The following is a description of a gene set: Mouse Gene Set: GOMF_PROTEIN_TRANSPORTER_ACTIVITY species: Mus musculus Directly binding to a specific protein and delivering it to a specific cellular location., and this is the list of marker genes: Tomm20l, Bcs1l, Tomm70a, Tomm40, Tmed10-ps, Gga3, Abca1, Pex13, Pex14, Sec61g, Timm29, Timm17a, Sec61a1, Tomm40l, Tomm22, Tomm20 (NCBI Gene Id 67952), Bloc1s3, Sec61a2, Igf1r, Lrp2, Atad1, Atp13a1, Lmbrd1, Afg3l2, Timm17b, Gpihbp1, Sorl1, Afg3l1, Sec63, Pex1, Pex6, Timm23, Tmed10, Timm22